Given this list of marker genes H4C14, H4C1, FIRRM, H2AJ, H2AX, H2BC21, H2AC20, H3C11, TEX15, H2AC19, H2BC10, H3C1 (NCBI Gene Id 8350, H3 clustered histone 1), H3C8, H2AB1, RAD51C, RPA1, H4C2, ATM, H3C3, CDK4, H3C12, RPA3, H2BC12L, H2BC5, H3C13 (NCBI Gene Id 653604), BLM, H2AC18, H4C11, CDK2, H2BC11, H2AC8, DMC1, H4C9, H2BC3, H3C14, H4C8, H2AZ2, H3-4, H4C15, TOP3A, H2BC26, MND1 (meiotic nuclear divisions 1), H3C6, H2BC1, RAD50, MRE11, H2BC8, H4C6, H3C10, H3C2, H3-3B, H2BC13, MSH5, SPO11, RBBP8, H2AC7, H2BC6, H2BC12, H2AC6, MSH4, NBN, H2BC7, H2AC14, H4C16, MLH3, H2BC4, H4C12 (NCBI Gene Id 8362), MLH1, BRCA1 (BRCA1 DNA repair associated), H3C4, BRCA2, H2BC17, H4C4, PSMC3IP, H4C3, PRDM9, RPA2, H3-3A, H4C5, H2BC9, H2AC4, RAD51, H3C15, FIGNL1, H3C7, H2BC15 (NCBI Gene Id 8341), H4C13, H2BC14, here is a description of the gene set: Meiotic recombination Human Gene Set: REACTOME_MEIOTIC_RECOMBINATION species: Homo sapiens